The following is a description of a gene set: Catalysis of the joining of two molecules via a carbon-carbon bond, with the concomitant hydrolysis of the diphosphate bond in ATP or a similar triphosphate. studied in species Homo sapiens Human Gene Set: GOMF_LIGASE_ACTIVITY_FORMING_CARBON_CARBON_BONDS, and this is the list of marker genes: ACACA, MCCC1, PCCA, PCCB, ACACB, PC, MCCC2